The following is a description of a gene set: Binding to heparan sulfate. Mouse Gene Set: GOMF_HEPARAN_SULFATE_BINDING studied in species Mus musculus, and this is the list of marker genes: Gfra2, Dmbt1, Tnfrsf11b, Ptn, Col11a1, Nrtn, Furin, Mdk, Ppia